Given this list of marker genes Rbm39, Pgap1, Ntrk2, Dtx1, Tirap, Daglb, Rasgrf1, Nkap, Ccne1, Nusap1, Camk1d, Gja8, Hira, Mdh1, Lrrc75b, Ermn, Tfdp1, Thsd7a, Dmac1, Slc6a1, Pclaf, Frem2, Gls, Slc17a6, Gnrhr, Slc25a24 (NCBI Gene Id 69910), Cds1, Abca1 (ATP-binding cassette, sub-family A member 1), Nme1, Vmp1, Dgkd, Gprin3, Tmem47 (transmembrane protein 47), Med27 (NCBI Gene Id 98820), Mtg1, here is a description of the gene set: from publication Chen Y, Wang X (PMID 31504780) Mouse Gene Set: MIR_463_3P studied in species Mus musculus Genes predicted to be targets of miRBase v22 microRNA mmu_miR_463_3p in miRDB v6.0 with MirTarget v4 prediction scores > 80 (high confidence targets).